Given this list of marker genes UBE2R2, PRKDC, PEX12, H2BC5, PEX10, RNF181, H2BC4, BCL10, SKIC8, UBA52, H2BC10, USP7, WAC, UBE2C, PEX5, PAF1, VCP, UBE2Q2, UBE2H, UBE2A, PCNA, UBC, H2BC15, RNF40, UBE2V2, UBE2J2, LEO1, DERL1 (NCBI Gene Id 79139), RNF144A, UBE2W, UBE2T, UBE2G1, PEX14, HLTF, H2BC3, HLA-A, RPS27A, H2BC14, RNF20, UBB, SELENOS, UBE2N, H2BC12, UBE2B, UBA1, UBA6, UBE2E1, RNF152, UBE2D2, H2BC9, H2BC6, CDC34, USP5, CDC73, RRAGA, CTR9, OTULIN (OTU deubiquitinase with linear linkage specificity), UBE2K, UCHL3 (NCBI Gene Id 7347), UBE2G2, H2BC17, RTF1, RAD18, SHPRH, H2BC11, UBE2E3, UBE2D1, TMEM129, PEX2, UBE2L3 (ubiquitin conjugating enzyme E2 L3), H2BC8, USP9X, PEX13, UBE2Z, UBE2D3, UBE2S, H2BC1, H2BC13, H2BC7, here is a description of the gene set: Protein ubiquitination species: Homo sapiens Human Gene Set: REACTOME_PROTEIN_UBIQUITINATION